Given this list of marker genes Igfbp3, Tnfaip6, Comp, Lilrb4b, 2300002M23Rik, Epha1, Mfap2, Ctss, Itga3 (NCBI Gene Id 16400), Ctsl, Tnc, Ccdc80, Lrrc15, Ssc5d, Thbs4, Igfbp5, Mmp9, Fstl3, Vegfa, Thbs1, Lilrb4a, Fbln1, Mmp2, Itgav (NCBI Gene Id 76358), Ccn2, Ctsk, Myoc, Itgb3, Sdc4 (NCBI Gene Id 99320), Igfbp6, Itga4, Mmp13, Itgb1, Hsd17b12, Loxl3, Plekha2, here is a description of the gene set: Mouse Gene Set: GOMF_FIBRONECTIN_BINDING species: Mus musculus Binding to a fibronectin, a group of related adhesive glycoproteins of high molecular weight found on the surface of animal cells, connective tissue matrices, and in extracellular fluids.